Given this list of marker genes MICAL1, GJA5 (NCBI Gene Id 2702), DNM1L, HSPB1, CSF1R, FAT2, NAGLU, PSEN1, VPS16, VPS13A, PKD2, CRYAB, PDE8B, CACNA1I, MYH6, UBA1, TGM6, OPTN, RAB39B, SAMD9L, MARCHF6, MARS1, ATXN10, SCN2B, TPM1 (NCBI Gene Id 7168), HLA-DQB1, NF1, POLG, MBD4, LAMA4, TRPM7, DNAJB4, MAP1B, CLCN2, TNNT2, MAK, PRNP, CCDC88C, TERT, VEZF1, REEP1, COQ4, H6PD, RPGR, APOA1, NAF1, HTRA1, ELOVL4, FHL1, MOCOS, ACTC1, CAV1, ANO5 (NCBI Gene Id 203859), PDGFRB, GYG1, SCO2, PDYN (NCBI Gene Id 5173), SPG11, TBX18, EPCAM, G6PD, CNBP, KCNC3, SDHD, GATAD1, RAF1, NOTCH2NLC, APOE, PSEN2, HMGCR, TGFBI, NEK8, KCNJ2, USP48, PRDX1, POLRMT, TENM4, KCNJ18, HKDC1, BAP1, GANAB, DSC2, TIA1, NOTCH3, CDH2, TTLL5 (NCBI Gene Id 23093), CLN6, SCN1B (sodium voltage-gated channel beta subunit 1), MARS2, DAB1, MME, MYORG, JAK2, PSAP, GBE1, TAPBP, LMX1B, FBLN5, SEC23B, FARS2, HAVCR2, PLEKHG5, DNMT1, DYRK1B, SPTLC2, DES, CTNNA1, CLEC3B, EIF2AK4, BRCA1, CADM3, LRIF1, MATR3, CHRNA1, UMOD, MIEF1, NOL3, TRPM3, DSG2, EIF4G1, TSPOAP1, TNNC1, NRL, DRD5, RRM2B, KCNQ1, HNRNPA1, MMACHC, TTC19, ATP2B2, CFH, SMAD2, PKHD1, APPL1, IKZF1 (NCBI Gene Id 55429), MAFA, CAPN3, FTL, KLHL7, AP5Z1, RP1L1, PRKN, BAG3, MFSD8, CHCHD2, MYPN, LYZ, KIF1B, SNCA, SOCS1, JPH3, CCNF, MAPT, AAGAB, WASHC5, RNF170, APP, CHMP2B, PDK3, APC, SMPD1, NEK1, CMPK2, THSD1, RRM1, VAPB, AARS1, RELN, BMP6 (bone morphogenetic protein 6), UBQLN2, POT1, CASK, COL4A1, ITM2B, TMEM240, UQCRC1, GNB4, VPS13C, SDHA, KCND3 (potassium voltage-gated channel subfamily D member 3), TBK1, RNASEH1, RBM12, FKTN, OXGR1, RIPOR2, VCL (NCBI Gene Id 7414), TK2, FLNC, PLN, ATN1, ANXA11, ABCC9, CYP7B1, PHKA1, SMPX, MSH2, HGSNAT, ATP6AP2, CHCHD10, ITPR3, KCNK3, ZNF408, CYLD, SCN5A, PIGT, LOX, ERBB4, MLH1, BMPR2, STT3A, LRP12, TOR1A, BVES, SNORD118, TNNI3, FDPS, TBP, NT5C3A, FBN1, DGUOK, ELOVL5, ANO10, KIF5A (NCBI Gene Id 84710), SFTPA1, IMPG2, KCNA5, KCNE2, SAMD7, ITPR1, MPZ, SLC37A4, RPA1, TUBA4A, THSD4, LMNA, KNG1, GBF1, MSH3, PDGFB (platelet derived growth factor subunit B), UNC119, RAX2, LITAF, NEXN, LGI1, VRK1, SCN3B, PYGM, BBS2, NPPA, CORIN, VCP, NPTX1, AARS2, NEFL, TTN, here is a description of the gene set: A type of adult onset with onset of symptoms at the age of 40 to 60 years. Middle age onset Human Gene Set: HP_MIDDLE_AGE_ONSET studied in species Homo sapiens